The following is a description of a gene set: species: Homo sapiens Sulfatase activity requires a unique posttranslational modification (PTM) of a catalytic cysteine residue into a formylglycine. This modification is impaired in patients with multiple sulfatase deficiency (MSD) due to defects in the SUMF1 (sulfatase-modifying factor 1) gene responsible for this PTM. SUMF2 can inhibit the activity of SUMF1 thereby providing a mechanism for the regulation of sulfatase activation. Reactome Pathway: The activation of arylsulfatases part of: Gamma carboxylation, hypusinylation, hydroxylation, and arylsulfatase activation, and this is the list of marker genes: ARSD, ARSA, ARSL, ARSI, ARSF, STS, ARSJ, ARSH, SUMF2, ARSG, SUMF1 (NCBI Gene Id 285362), ARSK, ARSB